Given this list of marker genes LGALS13, CCNP, ZNF780B, C19orf47, EID2B (NCBI Gene Id 126272), CLC, ZFP36, IFNL1, MAP3K10, GMFG, LGALS16, PAF1, FCGBP, PRR13P5, AKT2, FBL, TIMM50, LEUTX, MED29, ZNF780A, SAMD4B, RPS16, LRFN1, TTC9B, ZNF546, LGALS17A, EID2, SUPT5H, PSMC4, PLD3, PLEKHG2, DLL3, DYRK1B, SELENOV, LGALS14, here is a description of the gene set: species: Homo sapiens from publication Kuuselo R, Savinainen K, Azorsa DO, Basu GD, Karhu R, Tuzmen S, Mousses S, Kallioniemi A (PMID 17332321) Pancreatic cancer is a highly aggressive disease characterized by poor prognosis and vast genetic instability. Recent microarray-based, genome-wide surveys have identified multiple recurrent copy number aberrations in pancreatic cancer; however, the target genes are, for the most part, unknown. Here, we characterized the 19q13 amplicon in pancreatic cancer to identify putative new drug targets. Copy number increases at 19q13 were quantitated in 16 pancreatic cancer cell lines and 31 primary tumors by fluorescence in situ hybridization. Cell line copy number data delineated a 1.1 Mb amplicon, the presence of which was also validated in 10% of primary pancreatic tumors. Comprehensive expression analysis by quantitative real-time reverse transcription-PCR indicated that seven transcripts within this region had consistently elevated expression levels in the amplified versus nonamplified cell lines. High-throughput loss-of-function screen by RNA interference was applied across the amplicon to identify genes whose down-regulation affected cell viability. This screen revealed five genes whose down-regulation led to significantly decreased cell viability in the amplified PANC-1 cells but not in the nonamplified MiaPaca-2 cells, suggesting the presence of multiple biologically interesting genes in this region. Of these, the transcriptional regulator intersex-like (IXL) was consistently overexpressed in amplified cells and had the most dramatic effect on cell viability. IXL silencing also resulted in G(0)-G(1) cell cycle arrest and increased apoptosis in PANC-1 cells. These findings implicate IXL as a novel amplification target gene in pancreatic cancer and suggest that IXL is required for cancer cell survival in 19q13-amplified tumors. Human Gene Set: KUUSELO_PANCREATIC_CANCER_19Q13_AMPLIFICATION List of genes in the 19q13 amplicon region based on a copy number alterations study of a panel of 16 pancreatic cancer cell lines and 31 primary tumors.